The following is a description of a gene set: studied in species Homo sapiens Genes predicted to be targets of miRBase v22 microRNA hsa-miR-6869-5p in miRDB v6.0 with MirTarget v4 prediction scores > 80 (high confidence targets). from publication Chen Y, Wang X (PMID 31504780) Human Gene Set: MIR6869_5P, and this is the list of marker genes: UBE2V2, RGS21, ASL, RSPRY1, HMGB1, NAMPT, ANAPC11, CC2D1B, ZNF518A, FAM47A, API5, FOXM1, BRAT1, CYP4F2, SHROOM4, HAPLN1, VSTM4, PRR16, DNAI7 (NCBI Gene Id 55259), TRIM33 (tripartite motif containing 33), NDUFAF4, TBC1D12, ACSL4, ADI1, ITGBL1, RTKN2, RAP2C, PSMB5, TRPA1, XG, NKX3-2, ZFP91, CYP4F3, PAK1IP1, SDHC, CA10, SGMS1, WDR20, C2orf74, ZFP37, DIO2, PLPPR4, ZNF644, SCP2D1, POGK (pogo transposable element derived with KRAB domain), DMD